Given this list of marker genes SLC10A7, ALG12, POLR3A, IDUA, MTX2, CPLANE1, XYLT1, MTHFS, TBX4, IFT140, TAPT1, BMPR1B, BHLHA9, WNT7A, GDF5, CANT1, COL11A1, RAD21 (RAD21 cohesin complex component), SLC39A13, B3GALT6, RTL1, FN1, MEG3, FGFR3 (fibroblast growth factor receptor 3), TMEM67, SUCLG1, PEX5, COL9A1, AIFM1, PUF60, CFAP410, CCN2 (NCBI Gene Id 1490), POP1, RNU4ATAC, COMP, SALL4, TBX15, CHST3, NANS, MBTPS1, GNPNAT1, AMMECR1, SLC26A2, RAB34, SLC31A1, RSPRY1, SERPINH1, UBAP2L, AGPS, LBR, TGDS, CTC1, DLK1, CHD4, RUNX2, TRAPPC2, PIK3C2A, TRAF3IP1, FLNB, MATN3, TNFRSF11A, CCN6, IHH, DDRGK1, SHOX, COL2A1, TRPV6, PRG4, EXOC6B, IFNGR1, TONSL, TRPV4, MMP9, CAMK2A (calcium/calmodulin dependent protein kinase II alpha), POC1A, here is a description of the gene set: studied in species Homo sapiens Human Gene Set: HP_APLASIA_HYPOPLASIA_OF_THE_FEMUR Aplasia/hypoplasia of the femur Absence or underdevelopment of the femur.